The following is a description of a gene set: Any process that modulates the rate or extent of fever generation. Human Gene Set: GOBP_REGULATION_OF_FEVER_GENERATION species: Homo sapiens, and this is the list of marker genes: PTGER3, PTGES, TNFSF11, PTGS2, TNFRSF11A, TNF, EDNRB, IL1B